The following is a description of a gene set: A chromatin-associated multiprotein complex containing Polycomb Group proteins. In Drosophila, Polycomb group proteins are involved in the long-term maintenance of gene repression, and PcG protein complexes associate with Polycomb group response elements (PREs) in target genes to regulate higher-order chromatin structure. Mouse Gene Set: GOCC_PCG_PROTEIN_COMPLEX studied in species Mus musculus, and this is the list of marker genes: Aebp2, Scml2, Mtf2, Phf1, Skp1, Ezh2, Trim37, Chaer1, Rbbp7, Pcgf1, Phc1, Kdm2b, Rybp-ps, Csnk2a1, Epop, Ring1, Cbx4, Dnmt3l (DNA methyltransferase 3-like), Rybp, Zfp143, Yy1, Phc3, Pcgf2, Pcgf5, Bap1, Pcgf6, Ezh1, 9630013A20Rik, Asxl3, Csnk2b, Cbx7, Samd11, Rnf2, Eed, Cbx6, Asxl2, Bmi1, Phc2, Phf19, Csnk2a2, Sirt1, Hdac2, Rbbp4, Ubap2l, Samd7, Cbx8, Suz12 (SUZ12 polycomb repressive complex 2 subunit, NCBI Gene Id 74815), Asxl1, Cbx2, Zfp42, Jarid2 (jumonji and AT-rich interaction domain containing 2), Yy2 (NCBI Gene Id 100073351), Pcgf3